Given this list of marker genes SLC38A9, NOS1, TM4SF5, RARS1, NOS2, SLC7A6, CASTOR1, NOS3, CASTOR2, here is a description of the gene set: Human Gene Set: GOMF_ARGININE_BINDING studied in species Homo sapiens Binding to 2-amino-5-(carbamimidamido)pentanoic acid.